Given this list of marker genes Mdk, Cxcl17, Nr5a2, Pla2g5, Ppara, Irgm1, Adcyap1, Cx3cl1, Sod1, Tnfaip3, Slc39a8, Isl1 (ISL1 transcription factor, LIM/homeodomain), Il22b, Sbno1, Gpx2 (glutathione peroxidase 2), Tnfrsf1a, Gstp1 (NCBI Gene Id 14870), Hamp, Mefv, Alox5, Abr, Nt5e, Lgals9, Git1 (GIT ArfGAP 1), Dusp10, Socs3 (NCBI Gene Id 12702), Rb1, Tnfrsf1b, Pla2g10, Nlrx1, Cd200l2, Il17a, Fpr-rs6, Reg3g (regenerating islet-derived 3 gamma), Ptgis, Fam76b, Fpr-rs7, Ffar4, Smad3, Tafa3, Fndc4, Nlrp12, Gpr31b, Ins1, Macir, Clec12a, Npy, Il13, Fcgr2b, Ndfip1, Krt1, Wfdc1, Il10ra, Pglyrp1, Igf1, Tyro3 (NCBI Gene Id 98916), Pparg (peroxisome proliferator activated receptor gamma), Syt11, Ier3, Nfkb1, Lrfn5, Adora2a (adenosine A2a receptor), Proc, Nr1d2, Nlrp6, Nr1h3, Rora, Cyp19a1, Socs5, Nr1d1, Acod1, Mir7578, Otulin, Foxf1, Nr1h4, Enpp3, Il2ra, Pdcd10, Sharpin, Ptpn2, Extl3, Trim45, Trem2, Ada, Cst7, Il22ra2, Arnt, Ppard, Cdh5, Mvk, Psma1, Cx3cr1, Spn, Metrnl, Ctla2a, Fxr1, Reg3a, Fem1a, Aoah, Cd276, Dsg2, Sirpa, Cd200l1, Acp5, Fpr-rs4, Npy5r, Slamf8, Il20rb, Cd44, Chrna7, Psmb4, Smpdl3b, Muc19, Ash1l, Ldlr, Ptger4, Rabgef1, Apoe (NCBI Gene Id 11816), Gata3, Tnfaip8l2, Ghrl (ghrelin), C1qtnf3, Ccn3, Ptpn6, Il22, Nr1h2, Gpr17, Igtp, Zfp36, Ghsr, Vps35, Siglecg, Adora1, Ifnb1, Cd24a, Mir147, Il2, Elf4, Lpcat3, Selenos, Fpr-rs3, Grn, Pbk, Mfhas1, Gper1, Il10, Il22ra1, Cd200, Cyld, Bcr, Cd200r1, Gps2, Apoa1, Uaca, Irgm2, Il12b, Nr1h5, Ppp1r13l, Ahr, Fpr2, Ets1, Adipoq, Tnfaip6, Pf4, Ins2, Nlrc3, Il4, Trim65 (tripartite motif-containing 65), Nlrp3, Siglece, C1qtnf12, Tff2, Rps19 (NCBI Gene Id 20085), Tmsb4x, Gpx1, Mkrn2, Fem1al, Il33, Hgf, Stat3, Nod2, Foxp3, here is a description of the gene set: Mouse Gene Set: GOBP_NEGATIVE_REGULATION_OF_INFLAMMATORY_RESPONSE Any process that stops, prevents, or reduces the frequency, rate or extent of the inflammatory response. studied in species Mus musculus